Given this list of marker genes FAF2, MAP1LC3B2, TOMM70, CISD2, SQSTM1, MAP1LC3B, MAP1LC3A, PRKN, FKBP8, MAP1LC3C, HK1, CISD1, PINK1, here is a description of the gene set: Human Gene Set: KEGG_MEDICUS_VARIANT_MUTATION_INACTIVATED_P62_TO_PINK_PARKIN_MEDIATED_AUTOPHAGOSOME_FORMATION species: Homo sapiens Pathway Definition from KEGG: PINK1 -> PRKN -> (CISD1,CISD2,FAF2,FKBP8,TOMM70,HK1) // SQSTM1* // LC3 Mutation-inactivated p62 to PINK-Parkin-mediated autophagosome formation. Pathway ID: N01139. Pathway type: Variant. Pathway class: nt06464 Amyotrophic lateral sclerosis.